The following is a description of a gene set: Human Gene Set: GOBP_IMPORT_INTO_NUCLEUS The directed movement of substances into the nucleus. studied in species Homo sapiens, and this is the list of marker genes: NUP188, NPAP1, BCL3, MAVS, NUP93, HCLS1, HNRNPA1, NUP133, FAM53A, IPO8, ELAVL1, ING1, NUP88, AKT1, EFCAB7, SUFU, FAM53B, JUP, RANBP6, KPNB1, UBR5, STAT3, TRAF3IP2, NUP54, GCKR, KPNA5, TRIM28, POM121C, EPM2A, YWHAB, FERMT1, RAN, PHB2, IFNG, SMO, APPL2, CFL1, HEATR3, PRKD1, TPR, KPNA6, NUP107, HTATIP2, IPO7, IL33, LEP, TMCO6, CHP2, EIF4ENIF1, CABP1, POM121, KPNA1, SUMO1, RBM22, EI24, RGPD4, PSEN1, NUP58, ATF2, KPNA2, SIX3, GLI3, PML, RANBP17, LRRK2, BACH2, SEC13 (NCBI Gene Id 6396), ANGPT1, SPG11, HSPA12A, NF1, NUP214, SIX2, TARDBP (NCBI Gene Id 81927), POM121B, APOD, IPO11, DRD1 (dopamine receptor D1), CBLB (NCBI Gene Id 868, Cbl proto-oncogene B), JAK2, MAPK14, NUP85, SIRT6, ZC3H12A, POLA2 (DNA polymerase alpha 2, accessory subunit), NUP35, CDK1, NUTF2, IPO13, POM121L2, ADAR, KPNA7, SPRN, NUP153, IPO4, AKIRIN2, HSP90AA1, MBTPS1, ZIC1, CDKN1A, PIK3R1, RGPD5, SQSTM1, KPNA3, APPL1, FAM53C, FLNA, NUP155, PTTG1IP, RGPD2, HYAL2, RGPD1, STK4, TNPO3, HDAC3, RGPD8, CDAN1, TXNIP, SNUPN, FCHSD1, TSC2, IPO5, PPP1R10, SMAD3, ZPR1, EP300, RGPD3, CSE1L, NR4A1 (NCBI Gene Id 93352), XBP1, PRKAG1, PIK3R2, CWH43, TNPO2, MED1, UFM1, RANBP2, BAG3, RGPD6, CD36 (NCBI Gene Id 948), NPM1 (nucleophosmin 1), LMNA, PRICKLE1, NUP50, PKIA, BMP4, NFKBIA, NUP62, NUP98, RAB23, DMAP1, KPNA4, RPL23, TERT, HIKESHI (NCBI Gene Id 51511), CHP1, CDH1, TNPO1, TGFB1, IPO9, PKIG, TP53, KCNQ3, PPP3R1, PPP3CA, SHH, CRY2, SYK, MDFIC, PRKCD, E2F3, ABRA, STK3, FGF9, NOTCH1 (NCBI Gene Id 54781), MMP12, RPAIN, ECT2